The following is a description of a gene set: Genes predicted to be targets of miRBase v22 microRNA hsa-miR-3158-3p in miRDB v6.0 with MirTarget v4 prediction scores > 80 (high confidence targets). from publication Chen Y, Wang X (PMID 31504780) species: Homo sapiens Human Gene Set: MIR3158_3P, and this is the list of marker genes: ZNF74, ZNF135, MZF1, RIMS2, EIF3M, BRINP2, SHISA8, KNL1, EIF1AY, UBXN2B, WASF2, STAT3, RELN, ZSCAN16, MBTD1, BNIP5, FKBP1A, CENPI, HECW2, ZNF629, ZNF426, SFPQ, SNX27, CWC25, CAMKK1, CYP46A1, ZNF544 (NCBI Gene Id 27300), SLC23A2, WDFY3, ITGA4, ATM, RORA, DGKH, SOX5, TOX3, PCDHB4, PUS10, IL2, STRBP